The following is a description of a gene set: Human Gene Set: REACTOME_REGULATION_OF_ENDOGENOUS_RETROELEMENTS_BY_THE_HUMAN_SILENCING_HUB_HUSH_COMPLEX Regulation of endogenous retroelements by the Human Silencing Hub (HUSH) complex species: Homo sapiens, and this is the list of marker genes: H3C6, EHMT1, H2AC7, H2AC6, H4C9, H2AC14, H4C8, H3C7, H4C3, H3C15, ATF7IP, H2BC13, H4C15, H2BC5, RBM7, H2AB1, H2BC1, H2AC4, H4C4, ZCCHC8, H4C11, H3C3, H2BC6, H2BC21, H2BC12L, H2BC9, H2AC19, SETDB1, PPHLN1, H3C2, H2AC18, H2BC10, H2AJ, H2AZ2, H3-3B, MTREX, H4C14, H3C10, H2BC7, H3C8 (NCBI Gene Id 8355), H3C14, H3C11 (NCBI Gene Id 8354), H3C1 (NCBI Gene Id 8350), H2BC3, H4C6, H3C4, H2BC26, H3C13, H2BC12, EHMT2, H3-3A, H2AC8, H2BC11, H3C12, H4C16, MORC2, H2BC8, H2BC14, H4C12, H4C1, H2BC15, H2AC20 (NCBI Gene Id 8338), H2AX, H4C5, H2BC17, H4C2, TASOR, H2BC4, H4C13, MPHOSPH8